Given this list of marker genes MTM1, TAF9, RPL5, PABPN1L, USP9X, RPS7, CSNK2A1, CDKN2A, PANO1, PRMT6 (protein arginine methyltransferase 6), TRIM39, USP5, SMARCC1, DDRGK1, SHH, STYX, KLHL40, USP7, WAC, GIPC1, FHIT, BAG6, PHF20L1, UCHL5, PSEN1, USP14, CSNK2B, CAMLG (calcium modulating ligand), TLK2, ARHGAP5-AS1, N4BP1, PARK7, USP26, NOP53, PBK, CCAR2, RYBP, OGT, RPL11, MAP1A, WNT1, HFE, TTC36, QRICH2, EIF3H, SGTA, BAG5, RPL23, SUFU, CSNK2A2, TAF1, PML, SENP1, UBXN1, HSP90AB1, USP38, HIPK2 (NCBI Gene Id 653052), PDCL3, here is a description of the gene set: Human Gene Set: GOBP_NEGATIVE_REGULATION_OF_UBIQUITIN_DEPENDENT_PROTEIN_CATABOLIC_PROCESS species: Homo sapiens Any process that stops, prevents, or reduces the frequency, rate or extent of ubiquitin-dependent protein catabolic process.